The following is a description of a gene set: Reactome Pathway: CREB phosphorylation This event has been computationally inferred from an event that has been demonstrated in another species.<p>The inference is based on the homology mapping from PANTHER. Briefly, reactions for which all involved PhysicalEntities (in input, output and catalyst) have a mapped orthologue/paralogue (for complexes at least 75% of components must have a mapping) are inferred to the other species. electronically inferred by orthology from the curated human pathway studied in species Mus musculus part of: MAPK targets/ Nuclear events mediated by MAP kinases; Nuclear Events (kinase and transcription factor activation), and this is the list of marker genes: Rps6ka5 (NCBI Gene Id 73086)